The following is a description of a gene set: The process whose specific outcome is the progression of a cranial skeletal system over time, from its formation to the mature structure. The cranial skeletal system is the skeletal subdivision of the head, and includes the skull (cranium plus mandible), pharyngeal and/or hyoid apparatus. species: Mus musculus Mouse Gene Set: GOBP_CRANIAL_SKELETAL_SYSTEM_DEVELOPMENT, and this is the list of marker genes: Irf6, Mef2c, Gnaq, Chrd, Ift140, Wdr19, Tfap2a, Insig1, Runx2, Tulp3, Mmp14, Tgfb1, Slc39a3, Eif4a3, 2610005L07Rik, Chst11, Nodal, Frem1, Tifab, Msx2, Foxe1, Tbx15, Nog, Tbx1, Six2, Tgfbr1, Tmem107, Ric1, Prrx1, Neurog1, Bmp4, Rdh10, Cplane2, Sh3pxd2b (SH3 and PX domains 2B), Insig2 (insulin induced gene 2), Six1, Lrp2, Fgfr2, Pax5, Tgfb2, Nipbl, Wnt9b, Zic3, Gli3, Hoxa1, Gas1, Eif4a3l2, Foxn3, Hoxa2, Med12, Dlx1as, Twist1, Tgfb3, Ndst1, Crkl, Mthfd1l, Grhl2, Twist2, Smad3, Ednra, Gna11, Rab23, Dlx2, Ext1 (NCBI Gene Id 14042), Trp63, Megf8, Cep55, Prrx2, Tgfbr2, Fuz, Lhx1, Setd2, Pdgfra, Foxc2, Ctnnb1, Slc39a1, Eif4a3l1, Gnas, Fgf4, Fgf8, Smad2, Mmp16, B3glct, Irx5, Six4, Colec10